Given this list of marker genes MED13L, AKAP12, TCF12, DPYD, PTPRC, FKBP5, CD163, SP100, ARHGAP15, IL7R, here is a description of the gene set: Human Gene Set: LAKE_ADULT_KIDNEY_C30_IMMUNE_CELLS_MACROPHAGES from publication Lake BB, Chen S, Hoshi M, Plongthongkum N, Salamon D, Knoten A, Vijayan A, Venkatesh R, Kim EH, Gao D, Gaut J, Zhang K, Jain S (PMID 31249312) studied in species Homo sapiens